Given this list of marker genes CCDC175, ADGRD1, BFSP1, CRIPTO, MSI2, GALNT16, CHRND, CRISP2, SLC29A4, SDS, RASA2, ZNRF1, TGFB2, ITGA2B, LPIN3, NDRG1, AQP2, PCSK1 (NCBI Gene Id 5122), ICAM5, CRYBA4, TPMT (thiopurine S-methyltransferase), ZP2, BCL2L1, PLXNA3, IL11RA, PLAT, CUBN, DDO, RGS2, ATP8B3, ARPP21 (cAMP regulated phosphoprotein 21), SLC4A5, RPP25, SIL1, KRT31, CARTPT, BLNK, EFNA4, PLCL2, PYY, MOV10 (Mov10 RNA helicase), FTSJ3, NFKBIB, BHLHE40, SLC44A1, HDC, MBL2, GTF2B, FAM107B, NSG2, MARCKS, EXT1, NEDD9, FURIN, TCTE1, DSCAML1, FAM81A, LYSMD1, CLK3, ORM1, DLST, LRRK2, KRTCAP3, HEPH, FAM181B, TMEM39A, IGFBP6, GZMH, BCAS3 (NCBI Gene Id 89751), SMARCB1, BET1L, HTR3B, IL17RE, CPEB4, AEBP2, EBI3, BHMT2 (betaine--homocysteine S-methyltransferase 2), TIMP3, EML3, SERPINB9, ENO3, PSD (pleckstrin and Sec7 domain containing), GALNTL5 (NCBI Gene Id 168391), NUP54, FAH, ALX4, MMD, PLSCR1, IRS2, GSPT2, CHST14, LHX5, CDC42EP3, NR4A1, ISL1, MAP1B, TRAM1L1, PHGDH, INSL5, KTN1, SNTG2, GABRA3, NPVF, SPIN4, SLC22A23, SERPINB5, GPR85, PTPRG, SERPINC1, NPL, CCDC65, EDN1, IFNA1, GATA3, EHD1, AP2B1, SAA2, XCL1, TIMP4, LHX2, MRPL35, NSD1, PLPPR4, CCL22, UBXN10, DCN, TRPS1 (NCBI Gene Id 7227), OSGIN2, CFLAR, CASKIN2, ATF5, SEMA3F, SLC7A6, GLIS1, RAD51B, RAB20, APAF1, HELQ, POU3F3, CLDN5 (claudin 5), ARHGAP29, AVP, CBX2, IL17RB, ERN2, UPK3B, NEK2, PRKD1, EIF1B, CLMP, NTRK3, JUND, PROX1, DNAI4, NOL6, PDX1, BAZ2A (NCBI Gene Id 23525), IL1RN, NLRP6, ZNF264, TMPRSS4, CAPN2, OR10A4, PPP4R3A, ITGBL1, IL17RA, CCDC59, HPGD, CBY2, SHC1, C6 (NCBI Gene Id 12274), HILPDA, FEM1B, CCT5, HDHD3, MAN1A1, GRIK3, CRYAB, POLD1, EFNA2, HTR7, CALCOCO2, ISL2, IKZF4, FBXO45, COL4A6, CD247, RANBP17, THOC1, SLC12A4, ECE1, S1PR3, SYT1, CYP3A43, ZBTB48, RPL26, P2RX1, LOXL3, POF1B, TSPAN12, here is a description of the gene set: Genes up-regulated in comparison of dendritic cells (DC) stimulated with Pam3Csk4 (TLR1/2 agonist) at 2 h versus DC cells stimulated with Gardiquimod (TLR7 agonist) at 2 h. species: Homo sapiens mouse primary BMDCs were stimulated with tlr ligands and gene expression changes were profiled on Affymetrix arrays from publication Amit I, Garber M, Chevrier N, Leite AP, Donner Y, Eisenhaure T, Guttman M, Grenier JK, Li W, Zuk O, Schubert LA, Birditt B, Shay T, Goren A, Zhang X, Smith Z, Deering R, McDonald RC, Cabili M, Bernstein BE, Rinn JL, Meissner A, Root DE, Hacohen N, Regev A (PMID 19729616) Human Gene Set: GSE17721_PAM3CSK4_VS_GADIQUIMOD_2H_BMDC_UP